Given this list of marker genes GTF2B, PDLIM2, CBFA2T3, SHC3, NT5C2, ESM1, HYAL2 (hyaluronidase 2), APOLD1, HM13, SRPRA, GMPR2, KMT2A, CBLB, VPS39, GGNBP2 (gametogenetin binding protein 2), ITPR3, RWDD4, S100A10, MADD, ITPR2, ARL4C, NEDD4, STARD13, SPRED2, SLC9A9, ADNP, SH3BGRL (NCBI Gene Id 96022), ETF1, PLEKHH2, DPPA4, WDFY4 (WDFY family member 4), CACNA1D, LUC7L, TAF8, CSF2, DYNC1I1, RMI1 (RecQ mediated genome instability 1), IL13, IKBKB, ETV6, APBA1, CLEC14A, CNKSR1, ADAM11, TOR4A, GLB1L, PTK2, CHMP1B, PLA2G4F, CAMK1D, PPP1R9B, CPNE8, E2F3, OLFM1, ABCG1, FYN, FOXRED1, LIME1, UBE2L3, CYTOR, AGAP2, RAB43, APPL2, LOXL3, MTPN, ZNF384, SLC25A37, ZNF687, FOXO4, PAX6, MAGED1, BMP4, CAST, ITGA11, PSME2, TMEM256, EXTL2, KCNQ1DN, BAZ2A, NCEH1, MAP4K2, CEP83, PRSS27, TSC22D3, ORC4, ELOVL6, TMEM161B, LCP1, NHERF1, GALNT2, PIK3CG, UBTF, NDUFS2, RPS3, E2F5, LIMD2, TNNI2, CPXM1, TPP2, SLC16A2, TNS2, BIN3, DLGAP4, HOXA10, FOXO3 (NCBI Gene Id 2309), NME1, PDGFB, SOST, PABPC1, GLP2R, SLC30A7, GJA5, ADAM15, CCNJL, RNF31, RAP2C, GIMAP4, TREML2, HNRNPK, TMEM204, TRIM41, PTPN11, WDR53, ELK3, KDF1, LCP2, OMA1, FBXO36, IL1RAPL2, HOXC4, RLIM, CSRNP1, GPR150, ELMO1, ROCK1, EPN3, RUVBL1, PCDH7, RBMS2, ARL6IP6, SLC4A1AP, STK16, MAP4K4, NEDD8, NIPBL, CRADD, PML, LAG3, FOXP1, SNCAIP, LYN, SEPTIN1, PLCB2, CAP1, PUS7L, SASH3, TBC1D10C, LIF, LINC01565 (long intergenic non-protein coding RNA 1565), AMD1, HIC1, ARHGAP15, LCK, INCA1, STK10, WDR81, SPIB, DLC1, CORO1A, ACAP1, TGFB3, SLC7A1, STX5, RGS14, ST3GAL2, KLF13, ARHGAP45, RHOV, CANX, RGS3, POU2AF1, KLF12 (KLF transcription factor 12), DOK1, GIT2, MIDEAS, EGFLAM, NRG1, FFAR4, LYL1, RASA2, TRAPPC11, IMPDH1, WIPI2, TSC22D4, BCL2L2, MGAT4C, TTPAL, TSPAN1, SEC24C, ADAMTS4, PTBP3, ZNF800 (zinc finger protein 800), CD79A, TWIST1, KCNAB2, ARPP19, MMP3 (matrix metallopeptidase 3), LRRN3 (leucine rich repeat neuronal 3), HSD3B7 (NCBI Gene Id 80270), SDE2, LINC03040, SLC39A11, SLC12A4, MYH10, UBE2R2, TGIF2, TMEM71 (NCBI Gene Id 137835), DKK2, JUNB, SPRED1, ZNF205, CMTM6, ZSWIM8, GPR107, DAB2IP, ZNF35, PPP4R3C, FURIN, NAT14, SEMA4C, KCNQ1, PACC1, KIF1C, DPP3, VWA7, TFE3, DEF6, TMUB2 (transmembrane and ubiquitin like domain containing 2), FOXN3, RNF40, HOXA1, POLD4, BTBD16, POU3F4, FOSL1, TIMP4, FLNC, BDKRB2, MIR22HG, DHH, SCN2A, SLITRK1, TNFSF11, LANCL3, ZNF296, MAP9, ITPKB, TYRO3, DMTF1, SPNS3, HMGA1, KCND1, ZMAT3, RIPOR1, MCTP1, UBALD2, IL12B (NCBI Gene Id 7907), RGMA (repulsive guidance molecule BMP co-receptor a), here is a description of the gene set: studied in species Homo sapiens Genes having at least one occurrence of the motif RCAGGAAGTGNNTNS in the regions spanning 4 kb centered on their transcription starting sites. This matches the ETS1 transcription factor binding site V$ETS1_B (v7.4 TRANSFAC). Human Gene Set: ETS1_B